Given this list of marker genes Dlg4, Prkcg, Prkca, Ap2m1, Ap2s1, Cacng3, Nsf, Camk2b, Grip1, Cacng4, Ap2a1, Epb41l1, Ap2b1, here is a description of the gene set: electronically inferred by orthology from the curated human pathway This event has been computationally inferred from an event that has been demonstrated in another species.<p>The inference is based on the homology mapping from PANTHER. Briefly, reactions for which all involved PhysicalEntities (in input, output and catalyst) have a mapped orthologue/paralogue (for complexes at least 75% of components must have a mapping) are inferred to the other species. Reactome Pathway: Trafficking of AMPA receptors part of: Glutamate binding, activation of AMPA receptors and synaptic plasticity species: Mus musculus